Given this list of marker genes LRATD1, CWC27 (NCBI Gene Id 10283), F2R, PITPNM2, ARL15, here is a description of the gene set: from publication Chen Y, Wang X (PMID 31504780) Human Gene Set: MIR4749_5P species: Homo sapiens Genes predicted to be targets of miRBase v22 microRNA hsa-miR-4749-5p in miRDB v6.0 with MirTarget v4 prediction scores > 80 (high confidence targets).